The following is a description of a gene set: studied in species Homo sapiens Reactome Pathway: Activation of AKT2 part of: PI3K Cascade RAC serine/threonine-protein kinases (AKT, PKB) are serine/threonine kinases belonging to the cAMP-dependent protein kinase A/ protein kinase G/ protein kinase C (AGC) superfamily of protein kinases. They share structural homology within their catalytic domains and have similar mechanisms of activation. Mammals have three AKT genes, named RAC-alpha serine/threonine-protein kinase (AKT1, PKB, PKB-alpha), RAC-beta serine/threonine-protein kinase (AKT2, PKB-beta and RAC-gamma serine/threonine-protein kinase (AKT3, PKB-gamma, STK2). All share a conserved domain structure: an amino terminal pleckstrin homology (PH) domain, a central kinase domain and a carboxyl-terminal regulatory domain that contains a hydrophobic motif that is characteristic of AGC kinases. The PH domain interacts with membrane lipid products such as phosphatidylinositol (3,4,5) trisphosphate (PIP3) produced by phosphatidylinositol 3-kinase (PI3-kinase). Biochemical analysis. The PH domain of AKT binds to PIP3 and PIP2 with similar affinity. The kinase catalytic domain of Akt/PKB is highly similar to other AGC kinases (Peterson & Schreiber 1999). Phosphorylation of a conserved threonine residue in this region (T308 in AKT1) results in partial activation. The carboxyl terminal extension has the hydrophobic motif FPQFSY. Phosphorylation of serine or threonine residue in this motif is necessary for full kinase activation. Deletion of this motif completely abolishes activity., and this is the list of marker genes: PDPK1, AKT2, THEM4, TRIB3